Given this list of marker genes Emg1, Fdxacb1, Nsun5, Mettl15 (methyltransferase like 15), Bud23, Nop2, Mettl16, Trmt112, here is a description of the gene set: Mouse Gene Set: GOBP_RRNA_BASE_METHYLATION studied in species Mus musculus The addition of a methyl group to an atom in the nucleoside base portion of a nucleotide residue in an rRNA molecule.